The following is a description of a gene set: Human Gene Set: WP_GASTRIC_ACID_PRODUCTION species: Homo sapiens Gastric acid production, and this is the list of marker genes: VIP, GAST, GRP, PGA5, PGA3, PGC, SCT, CBLIF, PGA4, MUC6, CCK